Given this list of marker genes CLEC10A, ALPK1, CLN5, CLEC4M, LMAN2L, LGALS9, PYGL, SLC2A8, PAM, P3H1, P4HTM, LMAN1 (NCBI Gene Id 3998), HK2, DPM1, MBL2, CD207, TALDO1, HK1, LMAN1L, CLEC4G, G6PD, PLOD1, FUOM, COLEC12, SLC2A5, ALKBH3, ALDOA, CLEC6A, CD209, CLEC4A, PFKL, GYS1, COLEC11, PFKM, BSG, COLEC10, EGLN3, HK3, SLC2A3, MRC1, P3H2, ASGR2 (asialoglycoprotein receptor 2), PHYH, OGFOD1, ASGR1, P4HA2, P3H3, EGLN2, P4HA1, P4HA3, GCK, CLEC4D, SELP, ACR, GALK1 (NCBI Gene Id 2584), IGF2R, EGLN1, PKLR, DBH, ENG, KHK, PLOD2, ALDOB, CLEC17A, PLOD3, LMAN2, FBP1, OGFOD3, RPIA, GPI, UGP2, OGFOD2, HKDC1, here is a description of the gene set: studied in species Homo sapiens Human Gene Set: GOMF_MONOSACCHARIDE_BINDING Binding to a monosaccharide. Monosaccharides are the simplest carbohydrates; they are polyhydroxy aldehydes HnC(=O)H or polyhydroxy ketones HnC(=O)mH with three or more carbon atoms. They form the constitutional repeating units of oligo- and polysaccharides.